The following is a description of a gene set: Genes down-regulated in comparison of wild type CD8 effector T cells at day 10 versus those from mice defficient for TRAF6 at day 10. Human Gene Set: GSE15750_WT_VS_TRAF6KO_DAY10_EFF_CD8_TCELL_DN species: Homo sapiens CD8 T cells play a crucial role in immunity to infection and cancer. They are maintained in constant numbers, but upon stimulation with antigen undergo a developmental program characterized by distinct phases encompassing the expansion and then contraction of antigen-specific populations, followed by the persistence of long-lived memory cells. Although this predictable pattern of a CD8 T cell response is well established, the underlying cellular mechanisms regulating the transition to memory remain undefined. Here we show that TRAF6, an adapter protein in the TNF-receptor (TNFR) and IL-1R/TLR superfamily, regulates CD8 T cell memory development following infection by modulating fatty acid metabolism. We show that mice with a T cell-specific deletion of TRAF6 mount robust primary CD8 T cell effector responses, but have a profound defect in their ability to generate memory. This defect is CD8 T cell intrinsic and is characterized by the disappearance of antigen-specific cells in the weeks following primary immunization. Microarray analyses revealed that TRAF6-deficient CD8 T cells from early timepoints following immunization exhibit altered expression of genes that regulate fatty acid metabolism. Consistent with this, activated CD8 T cells lacking TRAF6 are unable to upregulate mitochondrial β-oxidation in response to growth factor withdrawal in vitro. Treatment with drugs that induce fatty acid oxidation enabled CD8 T cell memory generation in the absence of TRAF6. Remarkably, these treatments also increased CD8 T cell memory in wild type mice, and consequently were able to significantly improve the efficacy of an experimental anti-cancer vaccine. from publication Pearce EL, Walsh MC, Cejas PJ, Harms GM, Shen H, Wang LS, Jones RG, Choi Y (PMID 19494812), and this is the list of marker genes: LRRC66, IRGQ, PDC, MAP9, TRPM6, VWA1, NRAP, RAD51B, EGR4, ATRNL1, PLEKHG3, RNF13, WNK4, SPRY1, FRS3 (fibroblast growth factor receptor substrate 3), YEATS4, SPATS2, REG1B, P2RY4, TNPO2, FAM229B, EPS8L3 (EPS8 signaling adaptor L3), SOX13 (SRY-box transcription factor 13), IL17RB, DRD3, KIF26B, MAP1LC3B, SLC12A5, PLAC8L1, CCDC175, CTCF, EPHX4, BRAF, BMP4, STEAP3, RS1, C11orf65, MGMT (O-6-methylguanine-DNA methyltransferase), MINAR2, HLX, SLC1A7, CMTM2, CRABP1, KLRC2 (NCBI Gene Id 3822), TMEM63B (transmembrane protein 63B), ASIC1, UPK2 (uroplakin 2), CHRNB1, ACTRT1, NUDT16L1, LMOD3, SUMF1, SIX4 (NCBI Gene Id 51804), PLEKHH3, CLCF1, NAV2, PIGA, DNAAF11, RMI2, HOGA1, FXYD2, AMIGO2, HEPACAM, PRPF40B, SPACA7, CTSC, ENSG00000285566, RTL3, FLT1, IFT122, SDK1, KRT79, KIAA2013, KLHL14, DOCK6, ACSL3, UPP1, RASGRP4 (NCBI Gene Id 115727), DMBX1, SCEL, COL5A3, TMEM266, PXDN, ALDH1A3, SYT12 (synaptotagmin 12), SPRY2, FKBP9 (FKBP prolyl isomerase 9), GPX6, PKHD1L1, ASTL, PKDREJ, GRIP2, NAT14, PCDHB4, LUM, KHDC3L, GPR3, AIRE, H6PD (hexose-6-phosphate dehydrogenase/glucose 1-dehydrogenase), PACRG, SYBU, ZNF169, CPNE5, DCLK1, COL6A2, ACAP1, MRAP2, COL13A1, SLC7A4, DSCAML1, DUSP8, CISH, CLEC2L, SNCB, PIMREG, ASPHD2, NEU2, MST1R, CYTL1, HECW1, DOC2B, FBLN1, VANGL2, TMOD4, FLNC (NCBI Gene Id 2318), FGA, EPCIP, BAHCC1, TMPRSS2, EQTN, ADAM12, C15orf62, SLC4A11, VAX2, CAVIN4, ARMC2, KRT78, TOB1, CALCOCO1, CHST7, SEZ6L (seizure related 6 homolog like), UROC1, BMP5, RAG1, CCL17, SLITRK3, SPRY4 (sprouty RTK signaling antagonist 4), CORO2B, DGKH, IRS2, MAPK8IP2, C1orf210, TMEM102, DDAH2, COL11A1, PRRG4, THPO, GNAT2, HLF, MYO16, SEMA5B, KNTC1, RTN4R, GABRD, PABPN1, SLC24A4, OTOF (otoferlin), INCA1, NHERF1, TRIM66, CELSR2, CACNB1, TMEM88, EDN2, KCNU1, FAM178B, A2M, FGF10, CHRNA9, LCE2B, CNGA2, CYP26B1, CREB3L1, IFFO2, FUT10, ETV2, CFAP57, VGLL2, ZG16, CLPS, AKR1C2, LTK, SEMA4F, LOXL1, LCE3B, S100A14, DPYSL4, ROPN1, FOXM1, RLN1